The following is a description of a gene set: Pluripotent stem cells are undifferentiated cells posessing an abbreviated cell cycle, a characteristic profile of gene expression, and the ability to self-renew and generate all cell types of the body except extraembryonic lineages. They are a major cell type in the inner cell mass of the early embryo in vivo, and cells with the same properties, induced pluripotent stem cells, can be generated in vitro from differentiated adult cells by overexpression of a set of transcription factor genes.<br>Pluripotency is maintained by a self-reinforcing loop of transcription factors. In vivo, initiation of pluripotency may depend on maternal factors transmitted through the oocyte and on DNA demethylation in the zygote (recently reviewed in Seisenberger et al. 2013) and hypoxia experienced by the blastocyst in the reproductive tract before implantation. In vitro, induced pluripotency may initiate with demethylation and activation of the promoters of POU5F1 (OCT4) and NANOG. Hypoxia also significantly enhances conversion to pluripotent stem cells. POU5F1 and NANOG, together with SOX2, encode central factors in pluripotency and activate their own transcription. The autoactivation loop maintains expression of POU5F1, NANOG, and SOX2 at high levels in stem cells and, in turn, complexes containing various combinations of these factors activate the expression of a group of genes whose products are associated with rapid cell proliferation and repress the expression of a group of genes whose products are associated with cell differentiation.<br>Comparisons between human and mouse embryonic stem cells must be made with caution and for this reason inferences from mouse have been used sparingly in this module. Human ESCs more closely resemble mouse epiblast stem cells in having inactivated X chromosomes, flattened morphology, and intolerance to passaging as single cells. Molecularly, human ESCs differ from mouse ESCs in being maintained by FGF and Activin/Nodal/TGFbeta signaling rather than by LIF and canonical Wnt signaling. In human ESCs POU5F1 binds and directly activates the FGF2 gene, however Pou5f1 does not activate Fgf2 in mouse ESCs. Differences in expression patterns of KLF2, KLF4, KLF5, ESRRB, FOXD3, SOCS3, LIN28, NODAL were observed between human and mouse ESCs as were differences in expression of EOMES, ARNT and several other genes (Ginis et al.2004). part of: Developmental Biology species: Homo sapiens Reactome Pathway: Transcriptional regulation of pluripotent stem cells, and this is the list of marker genes: POU5F1, EPHA1, GSC, PRDM14, NR5A1, SMAD4, SMAD2, ZSCAN10 (NCBI Gene Id 9234), FGF2, SOX2, SALL1, EPAS1, FOXP1 (NCBI Gene Id 87246), EOMES, LIN28A, CRIPTO, HIF3A, DPPA4, SALL4, TSC22D1, ZIC3, STAT3 (NCBI Gene Id 6774), CDX2, PBX1, KLF4, DKK1, NR6A1, HHEX, FOXD3, GATA6, NANOG